Given this list of marker genes M, IGKV2-30, IGKV1D-39, E, IGLC7, IGHV2-5, MASP2, IGHV4-34, IGLV6-57, IGKV3-20, IGHG2, IGLV8-61, IGLV2-33, IGKV2D-30, IGKV1-12, IGKV3-15, IGKV1D-16, S, IGLV7-43, IGHV2-70, IGHV3-7, IGLV3-1, COLEC10, IGLV1-36, IGLV4-60, 7a, IGHV3-53, IGKV2D-28, IGKV2D-40, IGLV3-22, IGLV5-45, IGLV1-47, C1QC, IGKV1D-12, IGLV3-16 (immunoglobulin lambda variable 3-16), IGLV7-46, IGHV3-13, IGLC1, FCN3, IGKV3D-20, IGLC6, IGKC, COLEC11, C1S, IGHV3-9, IGKV3-11, IGHV1-69, N, IGHV3-33, IGLV2-14, IGLC2, IGKV4-1, IGKV2-29, IGLV4-3, IGLC3, IGLV, IGKV1-5 (immunoglobulin kappa variable 1-5), IGKV1D-33, IGKV1-16, SARS coronavirus, complete genome, IGLV1-44, MASP1, IGLV5-37, IGHV3-30, IGHV1-2, IGKV1-17, C1QA, IGKV2-28, 3a, IGHV7-81, IGLV2-23, IGLV1-40, IGLV2-8, IGLV2-18, CRP, C1R, IGKV1-33, IGLV3-12, IGLV3-19, IGKV1-39, IGHV3-23, IGLV11-55, IGKV5-2, C1QB, IGHV, IGLV2-11, IGHV4-39, IGHG4, IGHG1, IGLV4-69 (immunoglobulin lambda variable 4-69), IGHV4-59, IGHV3-48, IGHV3-11, IGLV1-51, IGLV3-27, IGHV1-46, IGHG3, MBL2, IGLV3-21, FCN2, IGLV3-25, IGLV10-54, FCN1, here is a description of the gene set: part of: Initial triggering of complement Two pathways lead to a complex capable of activating C4 and C2.<br><br>The classical pathway is triggered by activation of the C1-complex, which consists of hexameric molecule C1q and a tetramer comprising two C1r and two C1s serine proteinases. This occurs when C1q binds to IgM or IgG complexed with antigens, a single IgM can initiate the pathway while multiple IgGs are needed, or when C1q binds directly to the surface of the pathogen. Binding leads to conformational changes in C1q, activating the serine protease activity of C1r, which then cleaves C1s, another serine protease. The C1r:C1s component is now capable of splitting C4 and C2 to produce the classical C3-convertase C4b2a. C1r and C1s are additionally controlled by C1-inhibitor.(Kerr MA 1980)<br>The lectin pathway is similar in operation but has different components. <p>Mannose-binding lectin (MBL) or ficolins (L-ficolin, M-ficolin and H-ficolin) initiate the lectin pathway cascade by binding to specific carbohydrate patterns on pathogenic cell surfaces. MBL and ficolins circulate in plasma in complexes with homodimers of MBL-associated serine proteases (MASP). Upon binding of human lectin (MBL or ficolins) to the target surface the complex of lectin:MASP undergoes conformational changes, which results in the activation of MASPs by cleavage (Matsushita M et al. 2000; Fujita et al. 2004). Activated MASPs become capable of C4 and C2 cleavage, giving rise to the same C3 convertase C4b:C2a as the classical pathway. species: Homo sapiens Reactome Pathway: Creation of C4 and C2 activators